Given this list of marker genes Crybg1, Camk2a, Celf1 (CUGBP, Elav-like family member 1), B3galt6, Ephb1, Tma7, Pi4kb, Xpo6, Ccdc96, Terf1, Wiz, Tjp2, Car7 (carbonic anhydrase 7), Ryr2, Grhl3, Camta1, Zc2hc1b, Cdkl3, Morc2a, Zfp367, Fam124a, Dlg1, Setbp1, Fam76b, Nup62, Plekhm3, Asb10, Cyrib, Palld, Zdhhc16, Chd5, Slc39a4, Gypa, Chmp1b2, Sfxn3, Ttc28 (tetratricopeptide repeat domain 28), Bcat1, Cyp21a1, Ccdc92, Tmem52b, E2f7, Ptprk, Fut10, Gpr179 (NCBI Gene Id 544812), Susd6, Syn1, Tagln3, Atg4b, Atp6v0a4, She, Gtf2a2, Csmd1 (CUB and Sushi multiple domains 1), Abr, Rgn, Ube2g1, Ankrd17, C1ra, Krt80, Ankrd24, Limd2, Slc25a20, Sobp, here is a description of the gene set: species: Mus musculus from publication Chen Y, Wang X (PMID 31504780) Mouse Gene Set: MIR_7037_5P Genes predicted to be targets of miRBase v22 microRNA mmu_miR_7037_5p in miRDB v6.0 with MirTarget v4 prediction scores > 80 (high confidence targets).